The following is a description of a gene set: part of: Signaling by KIT in disease Reactome Pathway: KIT mutants bind TKIs Aberrant signaling by activated forms of KIT can be inhibited by tyrosine kinase inhibitors. Primary mutations in KIT are frequently found in exon 11, encoding the juxtamembrane domain responsible for autoinhibition of the kinase. These mutations are generally sensitive to tyrosine kinase inhibitors such as imatinib. Accumulation of secondary mutations in the ATP-binding pocket and the activation loop of the kinase domain contributes to resistance to first line tyrosine kinase inhibitors. KIT receptors with in these regions are sensitive to a panel of additional tyrosine kinase inhibitors such as sunitinib and regorafenib. studied in species Homo sapiens, and this is the list of marker genes: KIT